Given this list of marker genes FARP1, RASA4, POM121, UBE2K, ARSB, HLA-DMA, TRDMT1, IL2RB, STEAP2, VAMP2, MLLT6, FN3K, ST3GAL1, TRAK1 (trafficking kinesin protein 1), ATP2B2, RAB7A (NCBI Gene Id 7879), GET3, FLRT1, UCK2, ITGA5, IGF2BP1, GAS1 (growth arrest specific 1), CPNE5, MED17, GRK3, P3R3URF-PIK3R3, ZFP36L1, MKX, NUFIP2, ZCCHC13, RAB5B, LDB1, QSOX1, TRIM71, PHOSPHO1, NFIC, CASP3, PIAS3, GCOM1, EFHD2, CCDC43, PRKACA, ZBTB7A, ZNF529, NOVA2, DNM3, HSF2BP, SOX12, U2SURP, HEPN1, ZNF385A, CAMLG, KCNC3, SLC8A2, CMIP, HOXD13, HDAC9, ATXN1 (ataxin 1), ASB6, PLEKHB1, GDI1, SHOC2, MLLT11 (MLLT11 transcription factor 7 cofactor), TNFRSF11A, DDX17, BRPF3, SERTAD2, C9orf153, ACIN1, PRRC2C, GIGYF2, ZBTB7B, NDFIP2, ATXN7L3, DELE1, MECP2, GNAI3, TBR1, SLC39A5, HOXC5, MINK1, EFNA3, PTGIS, KIFBP, A1CF, HNRNPU, CBX6, BCL7A, COPG2, IQSEC2, B3GAT1, FBRSL1, ARK2C, BCL2L1, EIF4B, ELAVL2, MUC3A, TEAD2 (NCBI Gene Id 95515), RBPMS, QNG1, MAP4K4, AP1G1, AMT, PGM1, NAA11, CADM4, CX3CR1 (NCBI Gene Id 2836), CTNNA2, MYOG, DISC1, PGPEP1, NFIX, URM1, IMPA2 (NCBI Gene Id 3613), GAL3ST4, BMF, TUBB4A (NCBI Gene Id 1864), ZBTB7C, CALM1, ANGEL1, POLR2M, P2RY8 (P2Y receptor family member 8), MND1, HNRNPK, FBXL16, ATG2B, GINS2, PIK3R3, TMEM218, TMEM217, MSI2, CNN1, FXR2, ABHD18, MDK, CNTFR, here is a description of the gene set: species: Homo sapiens from publication Chen Y, Wang X (PMID 31504780) Human Gene Set: MIR6887_5P Genes predicted to be targets of miRBase v22 microRNA hsa-miR-6887-5p in miRDB v6.0 with MirTarget v4 prediction scores > 80 (high confidence targets).